Given this list of marker genes Bola2, Glrx5, Ciao1, Isca2, Ciao2b, Bola3, Ciao3, Ndufab1, Fxn, Bola1, Iscu, Lyrm4, Glrx3, Ciao2a, Nfs1, Fdx2, Mms19, here is a description of the gene set: A protein complex capable of assembling an iron-sulfur (Fe-S) cluster. Mouse Gene Set: GOCC_IRON_SULFUR_CLUSTER_ASSEMBLY_COMPLEX species: Mus musculus